Given this list of marker genes Or2p2, 8430406P12Rik, Gm25020, Trgj1 (NCBI Gene Id 100126431), 4930448F12Rik, Rala, Gm18859, Gm5446, Gm32036, Pou6f2, Yae1d1, Trgj3, Elmo1, Amph, Epdr1, Trgv6, Cdk13, Gm18363, A930027P06Rik, Gm7614, Vps41, Or2w1, Gm18065 (predicted gene, 18065), Gm5628, Vdac3-ps1, Trgv1, Gm7611, Mplkip, Gm7537, Gpr141b, Trgv7, Trgv4, Or2ad1, Gm32699, Gpr141, Sugct, Trgj2, Trim27, Gm18362, 9330199G10Rik, Gm17890, Stard3nl, Gm19154, Sfrp4, Gm6575, Trgv5, Gm18131, Gm26172, Trgv2, Aoah, Nme8, Gm24873, Trgc4, Mir466i, Or2w1b, Trgc1, Trgj4, Trgc2, Trgv3, Trgc3, Gm31887, here is a description of the gene set: Mouse Gene Set: chr13A2 species: Mus musculus